Given this list of marker genes NR6A1, MST1R, RIMS4, HOXA-AS2, SUSD3, SUSD2 (NCBI Gene Id 56241), SLC25A42, OR4D1, GDF5, LINC00347, AA06, OPTC (NCBI Gene Id 26254), PROX1, AFF3, DMPK (NCBI Gene Id 60405), FENDRR, SHARPIN, SERPINA5, TBC1D29P, BHLHE22, GABRG3, ACOXL, CNGA4, CHRDL1, RAB37, PCED1B-AS1, NOTCH4, SPANXA2-OT1, KLHL1, LINC00355, LINC02249, FOXR2, WWC1, TP53TG5, PGK2, ZFP36L2, TENT5A, PDE1A, EEF1A2, PDZK1P1, MYH15, NPAS2, EFNA3, FBLN5, TSNARE1, TMEM225, NR4A1, SLC4A1, BCAS4, PTCRA, TNFRSF13B, PGAP4, CFAP69, LRRC4C, GUCA2A, TRDN, TUT1, AKT1, NOX1, CRTAC1, STXBP5-AS1, TRIM15, SHISAL1, CSPG4P5, GNAT1 (G protein subunit alpha transducin 1), HCN3, SLC6A20, MNX1, MAP3K9, CPLX2, ARAP1, SMR3B, KRT34, KRT33A, CABP1, NT5E, TENM1, LHX9, ZPBP (NCBI Gene Id 91091), LINC02532 (long intergenic non-protein coding RNA 2532), APOB, MUC4, CES1P1, BRPF1, SMYD2, CRCT1, OR2F1, CX3CL1, CCDC63, ZBTB32, TMEM132A, RGS7, S1PR3, CRYGD, SFRP1, TMEM132E, LRWD1, SPTBN2, GRIK4, ADAM11, AGTR1, CCT8L2, PCGF2, CPEB3 (NCBI Gene Id 22849), TTC9B, SLC38A3, AMH, DDN, ADORA1, HTR7, TM6SF2, CETP, SH3D21, SIK1, TNN, FBXL9P, HPCA, GDNF, CHRNE, SLX9, NR2F1-AS1, METRN, CSPG4BP, ADRA2C, RGL2, TONSL, MUC6, DPYS, PIEZO1, PARD6A, HTR2C, AGPAT3, MAST1, FLJ30679, PRAMEF12, PRRX1 (paired related homeobox 1), BARX2, FBXO44, ELOA2, CALCA, ANKRD13B, MYEOV, CERS1, EOLA2, USP5, ILDR2, SPAG8, HBM, ZNF316, RNH1, PLXDC1 (NCBI Gene Id 57125), WDR87, GPLD1, MTUS2-AS1, PARD6G, LOXL1-AS1, EMCN, EVPL, SFXN3, COL18A1-AS1, DNASE1L1, SLC6A17, DAB2IP, FAM81A (family with sequence similarity 81 member A), LCN1, NEURL4, PCDHB9, BRF1, KY, ATP2B2 (ATPase plasma membrane Ca2+ transporting 2), CHRNA3 (cholinergic receptor nicotinic alpha 3 subunit), CCDC13-AS2, ADAMTS12, SNAP29, TNK2, MIP (major intrinsic protein of lens fiber), TMEM72-AS1, DCLK2 (doublecortin like kinase 2), AREG, PAX6, INSRR, PDZRN3, RND1, MORN4, WIPI2, GGT2P, FANCM, here is a description of the gene set: Genes up-regulated in peripheral blood monocytes (PMBC): healthy versus mixed infection sepsis. To identify signature genes that help distinguish (1) sepsis from non-infectious causes of systemic inflammatory response syndrome, (2) between Gram-positive and Gram-negative sepsis. Human Gene Set: GSE9960_HEALTHY_VS_GRAM_NEG_AND_POS_SEPSIS_PBMC_UP species: Homo sapiens from publication Payen D, Lukaszewicz AC (PMID 19535937)